Given this list of marker genes PHOX2B, SDHD, CCND1, HACE1, MYCN, SDHC, SLC25A11, LMO1, LIN28B, ALK, VHL, here is a description of the gene set: Elevated circulating catecholamine level Human Gene Set: HP_ELEVATED_CIRCULATING_CATECHOLAMINE_LEVEL species: Homo sapiens An abnormal increase in catecholamine concentration in the blood.